Given this list of marker genes Cdc37, Cct2, Spen, Cct6a, Cct7, Rbmx (RNA binding motif protein, X chromosome), Twf1, Msi2, Txnl1, Pde5a, Tmod3, Vim, here is a description of the gene set: part of: RHO GTPase cycle Reactome Pathway: RHOBTB GTPase Cycle species: Mus musculus This event has been computationally inferred from an event that has been demonstrated in another species.<p>The inference is based on the homology mapping from PANTHER. Briefly, reactions for which all involved PhysicalEntities (in input, output and catalyst) have a mapped orthologue/paralogue (for complexes at least 75% of components must have a mapping) are inferred to the other species. electronically inferred by orthology from the curated human pathway